Given this list of marker genes Flt3l, Brd7, Igfbp3 (NCBI Gene Id 16009), Trip4, Prl2c2, Tmem182, Mir489, Grem1, Gdf3, Rbpj, Sox9, Flot2, Myf6, Maml1, Actl6b, Mbnl1, Shh, Plekhm3, Sdc1, Myog, Pbrm1, Lrrc8a, Mef2c, Myocd, Il36g, Ilk, Ppard, Wnt10b, Ankrd2, Rb1 (NCBI Gene Id 19645), Mustn1, Ddx5, Neu2, Mapk12, Smarcb1, Map3k5, Zfhx3, T, Smarcd3 (NCBI Gene Id 78383), Igfn1, Arid1a, Mbnl3, Sox15, Xirp1, Tgfb1, Cxcl14, Rbm24, Itgb1, Tcf7l2, Ddit3, Hinfp, Bcl9l, Dll1, Mstn, Plec, Smarca2, Capn3, Cd53, Pitx1, Il18, Smarca4, Btg1, Ccl9, Actb, Id3, Smarcd1, Mkx, Ccl8, Myod1, Prickle1, Plcb1, Epas1, Smyd1, Boc, Mir351, Ripor2, Tbx3, Nrg1, Nr2c2, Phf10, Dicer1, Gpx1, Hif1an, Smarcd2, Cmtm5, Cxcl10, Smarcc2, Actl6a (NCBI Gene Id 99742), Plg, Arid2, Lgals1, Kat5, Ddx17 (NCBI Gene Id 97974), Smarcc1 (NCBI Gene Id 20588), Tnf, Megf10, Wnt3a, Bcl9, Cxcl9, Sox8, Notch1, Nmrk2, Akirin1, Xkr8, Rest, Myf5, Ccl17, Dubr, Pik3r1, Zfp36l1, Tbx2, Isl1, Klhl41, Tnfsf14, Sox4 (SRY (sex determining region Y)-box 4), Csrp3, Bmp4, Sra1, Igf1, Sostdc1, Mapk14, Fgf6, Cdon, Ranbp3l, Smarce1, Dpf3, Eid2b, Nol3, Srf, here is a description of the gene set: Mouse Gene Set: GOBP_MYOBLAST_DIFFERENTIATION The process in which a relatively unspecialized cell acquires specialized features of a myoblast. A myoblast is a mononucleate cell type that, by fusion with other myoblasts, gives rise to the myotubes that eventually develop into striated muscle fibers. studied in species Mus musculus